Given this list of marker genes CRHBP, MLNR, CMKLR2, GHSR, ABHD2, SHC1, RXFP2, ATP1A3, NRDC, CRHR2, MC1R, CRYM, PTH1R, CALR, PDE3A, MC3R, CDH13, AMHR2, EGFR, CRHR1, ADRA2A, MCHR1, GALR3, MTNR1A, CTSH, LEPR, GALR1, HCRTR1 (hypocretin receptor 1), GALR2, ALDH1A3, RAMP1, HCRTR2, C2CD2L, EDNRB, PTH2R, ALDH1A1, ACVR1, DRD4, ATP1A2, APP, NPY4R, CALCR, GLP2R, RAMP2, GCGR, LHCGR, AVPR1A (arginine vasopressin receptor 1A), VIPR2, SULT2B1, SLC39A9, VIPR1, CSF2RA, SEC61B, CCKBR, PRLR, SCTR, INSR, LRP2, PIK3R1, ADRA2B, CMKLR1, SHBG, ADRA2C, ADIPOR2, CCKAR, INHBA, RNLS, NR3C1 (NCBI Gene Id 389335), ECE1, ADRB3, TSPO, IDE, GHRHR, ATP1A1, SLC40A1, MC5R, NPR2, CALCRL, THRA, TTR (transthyretin), AR, GIPR, RXFP1, GHR, GLP1R, UCN2, ADIPOR1, ADCYAP1R1, IGF1R, FSHR, NPR3, GPER1, NPR1, THRB, IL23R, here is a description of the gene set: Binding to an hormone, a naturally occurring substance secreted by specialized cells that affect the metabolism or behavior of cells possessing functional receptors for the hormone. Hormones may be produced by the same, or different, cell as express the receptor. Human Gene Set: GOMF_HORMONE_BINDING studied in species Homo sapiens